Given this list of marker genes ALDOA, SLC4A1, HBA2, GPI, PIEZO1, HK1, HBA1, KCNN4, HBB, here is a description of the gene set: species: Homo sapiens Human Gene Set: HP_NONSPHEROCYTIC_HEMOLYTIC_ANEMIA Nonspherocytic hemolytic anemia